The following is a description of a gene set: studied in species Mus musculus Mouse Gene Set: REACTOME_TP53_REGULATES_TRANSCRIPTION_OF_GENES_INVOLVED_IN_CYTOCHROME_C_RELEASE TP53 Regulates Transcription of Genes Involved in Cytochrome C Release, and this is the list of marker genes: Triap1, Steap3, Prelid1, Prelid3a, Bnip3l, Zfp420, Atm